The following is a description of a gene set: The progression of the glomerulus over time from its initial formation until its mature state. The glomerulus is a capillary tuft which forms a close network with the visceral epithelium (podocytes) and the mesangium to form the filtration barrier and is surrounded by Bowman's capsule in nephrons of the vertebrate kidney. The glomerulus is part of the nephron and is restricted to one body segment. species: Mus musculus Mouse Gene Set: GOBP_GLOMERULUS_DEVELOPMENT, and this is the list of marker genes: Ednra, Bcl2, Myo1e, Notch1, Foxc2, Itgb3, Osr1, Hes1, Klf15, Mef2c, Jag1, Tek, Pdgfb (platelet derived growth factor, B polypeptide), Adipoq, Bmp7, Lamb2, Agtr2, Pax2, Podxl, Ppp3ca, Plce1, Hc, Nphs1, Actn4, Sulf1 (sulfatase 1), Ptpro, Lhx1, Cfh, Foxc1, Enpep, Aqp1, Gpr4, Nid1, C3ar1, Pdgfd, Edn1, Prom1, Asxl1, Notch2, Iqgap1, Ahr, Foxj1, Tcf21 (NCBI Gene Id 21412), Comt, Lgr4, Ret, Cflar, Serpinb7, Pdgfra, Pdgfrb, Mtss1, Ext1, Sulf2, Pdgfa, Il6ra, Bmp4, Nog, Magi2, Col4a3, Ctnnd1, Wt1, Ifng, Cd2ap, Wwtr1, Cd24a, Nphs2, Cd34, Ednrb, Notch3, Basp1, Ampd2, Mpv17, Col4a4, Angpt2, Acta2 (actin alpha 2, smooth muscle, aorta), Kirrel3, Heyl, Egr1, Angpt1, Vangl2